Given this list of marker genes FCGR3A, GCNT2, ETNK1, GPR15, PSMB9, SLC9A3, SPRY2, NUS1, PLA2G7, OSM, CLMP, MSR1, TMEM37, BEND3, CCRL2, PMP22, TPCN2, ECHS1, P4HA1, VCAN, SMOX, MMP8, GLIS3, ETV5, C1GALT1C1, FABP5, HIPK2, PTGER2, SLC6A12, KDM7A, RIPK3, PLBD1, ANKRD50, KDM6B, CD74, LTB4R, TMEM243, JUNB, PHLDA1, GOT1, GRK6, GNGT2 (NCBI Gene Id 2793), TRIM25, S1PR1, LITAF, TMEM106B, AZI2, TUBB6, TSPO, HELZ2, HP, EGR2, FBXL5, SERPINB2, NR1D2, P2RY14, PCK1, MGST2, CHRNA3, SVIL, SGMS2, GCLC, GBP6, GCA, PGRMC1, SLPI, SNORD89, TANC2, IRF2BPL, AIG1, CD274, MMP9, NFIL3, DPY19L1, F10, DIPK2A, BRWD1, TMEM204, CCL5, ZNF503, TGDS, CEP57, CD164, CHCHD10, DMXL2, PARP14, TENM1, ARG1, PAG1, RAI14, ARNT, LAMP2, MTHFD2L, TGIF1, CCNL2, SNX24, MYO10, IFITM3, XDH, CYTIP, MCFD2, DTNB, TCP10L, NLRC5, GDI1, RNASEL, C1R, CNDP2, SLC15A3, GDE1 (glycerophosphodiester phosphodiesterase 1), SCAMP1, UCMA, RAP2A, HLA-C, FPR1, IKBKG, CD1D, FABP4, MMP12, PRKAA1, ETHE1, MYL12B, PHYHD1, TF, SRGN, PLEKHA3, KCNK13, CRTAP, H1-2 (NCBI Gene Id 3006), LONRF3, PLXDC2, NR3C1, TPST1, BTG3, CD86, AKAP7, GAS2, FNDC3B, FAM43A, DNAH2, CXCL6, NUFIP1, MBD2, RCBTB2, EIF5, SLC25A30, MFAP3L, BST1, AHRR (aryl hydrocarbon receptor repressor), MCOLN2, GJA1, APMAP, ARHGAP6, ATF4, ARRDC3, TPD52, INHBA, PRDX5, ARG2, LRRC8D, MARCO, JAG1, MOV10, PLA2G4A, PLPP3, FGR, FREM2, APP, MAFB (NCBI Gene Id 9935), LPAR1, GADD45A, TMEM248, PTTG1IP, ABHD5, EGR1, GSTM1, RAB12, CCDC126, DYNC2H1, SERPINB8, GCH1, FLRT3, SMIM3, FTH1, IL6ST, FPR2, TMEM171, H3C14, B4GALNT2 (NCBI Gene Id 124872), AKR1C3, NEAT1 (NCBI Gene Id 283131), IL7R, PLEKHG1, SLC16A1, UBXN2A, COL19A1, SNAI3-AS1, P2RY13, GPX4, FCGR2A, here is a description of the gene set: from publication Mold JE, Venkatasubrahmanyam S, Burt TD, Michaëlsson J, Rivera JM, Galkina SA, Weinberg K, Stoddart CA, McCune JM (PMID 21164017) Human Gene Set: GSE25085_FETAL_LIVER_VS_FETAL_BM_SP4_THYMIC_IMPLANT_DN Genes down-regulated in thymic implants from fetal liver versus those from fetal bone marrow. species: Homo sapiens Human fetal and adult hematopoietic stem cells (HSC) were obtained from fetal liver, fetal bone marrow (BM), and adult BM. These were injected into human fetal thymic implants in SCID-hu Thy/Liv mice (4-6 separate mice per HSC donor) and allowed to mature into single positive CD4+ (SP4) thymocytes over the course of 7-8 weeks. SP4 thymocytes from injected stem cells were subsequently sort-purified from thymic implants and gene expression was performed.